Given this list of marker genes C2cd2l, Pik3r1, Insr, Ide, Igf1r, here is a description of the gene set: species: Mus musculus Mouse Gene Set: GOMF_INSULIN_BINDING Binding to insulin, a polypeptide hormone produced by the islets of Langerhans of the pancreas in mammals, and by the homologous organs of other organisms.